Given this list of marker genes Ripk1, Birc3, Bok, Mutyh, Nol3, Casp8, Cflar, Cav1, Fadd, Nupr1, Map3k7, Rbck1, Peli1, Rnf31, Slc25a4, Birc2, Ybx3, Adprs, Fzd9, here is a description of the gene set: species: Mus musculus Any process that decreases the frequency, rate or extent of programmed necrotic cell death. Mouse Gene Set: GOBP_NEGATIVE_REGULATION_OF_PROGRAMMED_NECROTIC_CELL_DEATH